Given this list of marker genes RNF4, GLYR1, SRF, GTF2A1, ARHGAP26, GAPLINC, EGLN2, TBCB, RNU2-2P, SYTL2, ELMOD3, HESX1, MRLN, CCDC136, AMD1, HS2ST1, KCNJ10, CNTD1, CAVIN2-AS1, VPS50, SNRNP40, TRIM29, UBE2F (NCBI Gene Id 23665), HNRNPH1, DAGLB, FBXO22, HSPBP1 (HSPA (Hsp70) binding protein 1), ATP5MC3 (ATP synthase membrane subunit c locus 3), B3GALT4, GATA6-AS1, MT-ND1, TCF19, LITATS1, ENSG00000235979, EXOSC9, CCNG2, PLCL2, BTNL8, LINC01393, KIAA1614, H2AC6, EDRF1, API5, IER3-AS1, SSTR5, LINC01719, LINC01833, DDX41, WDR7, TLE4, RNVU1-4, DPAGT1, CDHR3, HARBI1, INS, NOL9, LARP4B, PDHX, CNKSR3, SCRIB, C12orf76, PLK4, PRICKLE1, DHX16, RNU2-17P, LINC01767, INS-IGF2, RABGAP1L, ZBTB14, ABALON, RAB11A, BTBD3, HEXIM1, H3C1, UBB, BTBD3-AS1, ING1, GAS5, SNRPE, CNTN4, SCRT1, UTP6, GLYCTK-AS1, PRIM1, ZNF250, LDLRAP1, TMEM259, E2F5-DT, LINC01716, ZNF547, MT-RNR1, ANP32E, RNU7-1, MLXIPL, SSTR5-AS1, USP15, DCTN5 (dynactin subunit 5), HIPK1, VEPH1, SNAPC5, RMDN1, RNF139, YIF1A, GAB1, RHOA, MTCO3P12, MTHFD2L, TMCO1, LNC-LBCS, DHDDS (NCBI Gene Id 79947), KIF12, POR, PPFIA1, DDR1, SZT2-AS1, EPSTI1, DCLK1, ANKEF1, MIEF1, TCF4 (NCBI Gene Id 6925), FHAD1, CGGBP1, TARS2, LINC02417, RAB3GAP2, RNVU1-28, PPP1R37, HIPK1-AS1, ZNF181, RN7SL209P, AOAH, LPGAT1, ZBTB45, ZNF609, ZRANB3, ESCO2, UTP15, CYB5D1, ZSCAN31, JOSD2, KNL1, BRINP2, MARVELD3, RN7SL473P (RNA, 7SL, cytoplasmic 473, pseudogene), CCDC28A, C22orf46P, IGF2BP3, H4C3, PYCR3, VMP1, RNF139-DT, ARIH1, SOX6, ZNF277, NKAIN4, SNORD48, DLG2, C11orf54, MCCC1, OGT, ID4, CHGA, IER5, MAB21L4, METTL25, RAB3C, CCNH, BANCR, WEE2-AS1, FAM47E-STBD1, EIF2B5, PCYT1A, CLASP1, TLE6, RNU6-450P, UBR3, E2F5, ZFP64, ABLIM2, MUTYH, ZNRF2P3, BCKDHA, EIF3F, IREB2, GTF2H3, UPF3A, ADD1, DDX5, GPAM, DLGAP1-AS2, FOXI3, FAM76A, MTERF4, STK25P1, IDE, RNPEP, C2CD2L, IVD, FAM174C, ARID1B, CPS1, GTF2A1-AS1, MSANTD3, RRAS2, GEMIN6, PSME3IP1, ZSCAN20, ILRUN, MYLK, CLPTM1, LINC00663, KIF3B (kinesin family member 3B), LINC03002, PHB2, LINC01904, SGO1-AS1, ULK4, RPS27A, DAP-DT, TFEB, MBD1, ANXA2, RN7SKP192, ECE2, XPNPEP1, GNPDA2, SNHG11, ID1, RRP36, DHX32, GORASP2, ARID5A, IFT74, SRP68, MSI2, PKD1, EPC2, BRINP3, RMI2, TMEM177, RGS7, ENSG00000268129, GTF2H4, CTSB, TEAD1, MSI1, INO80, TM2D3, LCMT1-AS1, SLC34A1, VGF, FAM228B, PPARD, PLCE1-AS2, SEC22C, TMEM229B, H1-4, CYLD, CCDC88A, MEST, CCDC80, AATF, NBPF1, SRPRB, ENSG00000263280, GNLY, FKBP1A, LINC01320, TRAPPC12, DDX18, CAB39L, TCTA, IFT74-AS1, RMND1, CAPS2, RPL32P9, DHRS4L2, ENSG00000263080, MMP24OS, PRR5L, SNORD42B, U2SURP, HSPD1P18, ERMN, FAM47E, HOOK2, MIR3667HG, GLYCTK, FBRSL1, IZUMO4, RPL23A, VMAC, LRRC41, RNVU1-3, CCDC162P, SELENOF, FLCN (folliculin), SLC37A4, ABAT, SNHG29, KCNK16, SLC3A2, CITED2, ESYT1, ASH1L, INCENP, RAD52, RNU12, TXNDC9, MIR4259, KCNMB2, PPP2R5A, EIF2B1, LINC02351, EOLA1, TMEM41B, RAB3D, RDX, CLRN3, IDI1P1, SSBP1, EIF2A, ANKRA2, ZNF37A, STK35, APIP (APAF1 interacting protein), RPH3AL, KRT15, TMEM218, NBEA, POM121L14P, DHRS4L1 (dehydrogenase/reductase 4 like 1 (pseudogene)), KLC2-AS2, MIR367, PDZPH1P, PIGBOS1, ZNF490, TMCO1-AS1, EMC9, C4orf36, AASS, SMC4 (NCBI Gene Id 10593), C2CD3, LINC01828 (NCBI Gene Id 101927661), DKK3, TMEM205, LINC02447, EIF2AK3, RNVU1-30, LFNG, C12orf57, WDR11-DT, MED18, PABPC1L, CRIPTO, SNORA57, SDHAF3, PPME1, TMEM37, POLDIP3, SNORD68, LSM8, CPNE8, ELAPOR1, SART1, GTPBP8, VKORC1, INSM1, RRAGA, MTND5P11, TRMT10A, GALNT16, COX20, FABP1, PALB2 (NCBI Gene Id 79728), RPS21, AP4E1, SIRT4, MIR302CHG, UTP3, ALAD, OSBPL2, UPP2, RSAD1, CCNB1, RGS22, ACVR1, SYCE2, NDUFA11, SCHIP1, MT-TL1, LINC02418, PSMD1, MRPS14, NSL1, INO80B-WBP1, SF3A3, ZBTB40, RNU5D-1, GCNT2, LINC02226, ZRANB2-DT, ANK3, YTHDF2, CREB3L2-AS1, UMPS, CP, ATAD5, GMEB1, PRR3, PLA2G4E-AS1, NXN, EIF5B, WDR89, ZNF317, RND3, TMEM70, DGKE, EMG1, COPS3, ENSG00000253270, ITPR2, TTC33, WRAP53, PHLDA1-DT, FRMPD2 (FERM and PDZ domain containing 2), BRD4, GTSE1-DT, LINC01515, PDZD2, SERP1, ACOX2, REST, RGS5, ADAMTS20, R3HDML-AS1, THEM5, TADA1, DDX47, SNX16, ANKRD36, ENSG00000176984, RPL19, ALG3, TTBK2-AS1, SEMA6A-AS1, RPL7P6, ADGRA1-AS1, WDR25, RPS6KB2, TPM1, TUBB4B, GSK3B, P2RX6, ABCB1, TENM2, TADA3, ILRUN-AS1, TRIQK, CRTC2, RXRG, GIPC2, WDR27, MAP7, SNTN, MDH2, SRSF7, BDH2, FOXA2, EIPR1, RBM39, TIMP3, TRAPPC2B, PTX3, EPHA3, ODR4, FLOT1, AFP (alpha fetoprotein), MYL6B-AS1, CCHCR1, PIGB, KRBA2, MIR4487, NAGK, RPL21P42, WDR11, SLTM, S1PR5, UNC80, PCSK1 (NCBI Gene Id 5122), UQCRH, SIPA1L3, SLC35A2, GSTCD, EIF2B5-DT, H4C5, RAB1B, ENSG00000267568, RNU5F-1, MEG3, GC, RIC8B, ENSG00000199566, STC2, HMX3, RAD23A, KIF21A, OGA, TANK (TRAF family member associated NFKB activator), MAT2A, MIA3, VAMP4, SVOP, TMEM202-AS1, CDH22, EHD4, HEXIM2-AS1, LONP2, ZNF549, PHF19, WDR74, EXOSC5, ST18, HSD17B11, PHLDA1, HECTD2, CTXND1, CEP95, EIF3E, TLX2, UBE2F-SCLY, MOB3A, LINC02408, ZNF141, CNST, RNVU1-22, BSN, MIR4458HG, ARPC4, PIH1D1, ODF2L, CD164, HEY1, SAV1 (NCBI Gene Id 60485), COMT, ELF3, TMEM68, TTN-AS1, TRIM26, HDLBP, CDK12, MYL6B, RNVU1-27, STXBP1, SNHG1, SNORD26, RNVU1-21, CHGB, MYL6, TARBP2, ARPC4-TTLL3, MIDN, TMTC2, AFF1, ZNF608, EMB, RPS12, RNU6-601P, ATP5F1A, USP40, GID8, MIR302C, SNORD101, STAT1, PRKCE, CSE1L-DT, ZNF56P, SUPT5H (NCBI Gene Id 6829), FFAR1, NUSAP1, LINC01625, TP53I13, HDAC4, GLG1, STK19, HAS3, SYNGAP1, TCF12, GPC5-AS1, CCDC59, HMBOX1, CD68, RPL27A, SNORD3D, BSN-DT, TOMM40, ALKBH5, USP4, DIP2B (NCBI Gene Id 57609), ATG16L1, UBN1 (NCBI Gene Id 50641), RHOBTB3, SMG6, MIR302A, NRP1, VARS2, PRKCH, C4orf19, CSK, ALG10B, CENPU, RARB, ATP5PFP1, HGD, CCP110, KANSL3, ATP9B (ATPase phospholipid transporting 9B (putative)), CFAP276, THAP4, PTGER4, CAMK2N1, SLC46A2, AFG3L1P, SCIN, C11orf98, RGS4, MAP3K12, DDX46, DHRS4-AS1, KLF10, SNU13, TBL1X, TPR, MTFR2, TTI2, USP39, RNU4-2, FBXO46, LINC01363, ENSG00000223881, ZNF26, LRP12, CLHC1, NIN, VXN, CACUL1, ARHGEF28, UGT2B7, RNVU1-14, GRAMD2A, CNOT8, TMEM132C, FAM151B-DT, TOE1, RNU4-1, SMG7-AS1, USP54, MALAT1, TAOK1, THY1, RIF1, UBE2D1, ZNF302, EIF4E2, SMAD7, MTF2, SGK2 (NCBI Gene Id 51178), CAMSAP2, RNU5A-1, AURKA, TIMM22, KDSR, CDH8, SLC51B, OTX2, CCNO-DT, PRKRIP1, SHTN1, TAF4, SGK1, STAT3, NPL, LPCAT3, VCF1, MIR302D, UGP2, H3C10, INTS5, UAP1, DENND2A, SNAP23, ZMYND8, RPL13, TAB3, IGLVV-58, SMG7, NUMA1, CCDC159, SAC3D1, INTS6, RASGEF1B, RIOK2, KDM4A, LINC00870, CNRIP1, POLG2, PTPN1, ZNF791, FRS3, TMEM126B, MLX, LINC00970, SNHG32, SGO1, BCAR3-AS1, ARMT1, SKINT1L, DNAAF11, OSBP, CSDE1, IGLV7-46, RNVU1-2A, DOCK4, MON2, LPGAT1-AS1, TIGD1, GTSE1, CCDC28A-AS1, KMT2A, FOXA3, NRXN3, INTS9, CARS2, CLCN3, MESTIT1, GSK3B-DT, LYNX1, ZNF385B, VOPP1, MYH10, PLEKHG2, TAF5, CLU, MIR5087 (NCBI Gene Id 100847044), PDCD6P1, CSKMT, WDR5B-DT, APRT, EEF1A1, TGS1, MIR5695, NPEPL1, GBA1, LCMT1, CCNO, LINC01484, SRA1, ANAPC13, B4GALNT3, INPP4B, CBX3P9, SEC31A, COX17P1, GFOD2, DDAH2, NDUFS1, TXK, TUBB8, ZC3H12A, HSD17B6, PRDX1, ELF3-AS1, SGPL1, RABGAP1, SF3B6, CNBD2, DDIT4, MTTP, MRPS15, RNU6ATAC, TCF3, HEXIM2, HJURP, TAF1D, DYNC2I2, INTS6-AS1, RNU5B-1, ELOC, POLR1H, RGL3, MIR3183, LRRC51, MIR4673, PDZK1 (NCBI Gene Id 96133), MIR1224, POU2F1, NAA38, HNF4A, DNAH12, EPAS1, DIDO1, POLR2A, SNORD25 (small nucleolar RNA, C/D box 25), ZNHIT3, NEAT1, ENSG00000249574, WDR5B, MSH4, MEIS2, ZC3H10, ZSCAN2, ACVR1B, MAP2K6, PTPRK, ADCY9, C1orf21, RBBP5, SYMPK, VCPKMT, CCSER2, CRYZL2P-SEC16B, LINC00680, SPOCK2, NRBP1 (NCBI Gene Id 29959), PHLDB2, ASXL3, MAN1C1, LINC01972, INTS12, MOB1A, H4C2, SYBU, ENDOG, GADD45B, BUD31P1, IL34, GNL1, PDE4D, FHOD3, MPDU1-AS1, TANK-AS1, COPZ1, NALF1-IT1, SP1, DHRS4, ZNF106, ZBTB4, CAST, RETSAT, ARB2A, DXO, RNU4ATAC, ZNF329, IGSF11, PNPLA6, GATA4, HSP90AB1, FANCL, MT-TP, DNAJB4, SNORD49B, EDRF1-DT, SETDB2, COX7A2L, RHOC, STK10, EIF2AK4, NFASC, GRIK4, DPP9, SNHG5 (small nucleolar RNA host gene 5), HSD17B1, ENSG00000283078, MTCH1, TES, GREM1, CCDC150, ATG13, INO80B, POLR2M, MAP1LC3BP1, STPG1, SYT7, PRICKLE2-AS3, ANK2, EIF3A, NOL4L (NCBI Gene Id 63890), CFAP410, RHOBTB1, TATDN3, NUF2, LRIF1, BMF, TNRC6C, CRYZL2P, SNORA66, MT-TF, DDX52, MIR4512, MBD3 (NCBI Gene Id 8931), ALG14, CCDC192, ZBTB37, RAB27A (NCBI Gene Id 5873), HAUS2, CSTF1, FAM151B, FOXP4, CEBPB-AS1, POU6F2, C3orf38 (chromosome 3 open reading frame 38), GDF15, MECOM, PDE4DIPP6, JTB, CEP63, POLR1HASP (NCBI Gene Id 80869), ARL15, LENG8, BOLA1, NAV2 (neuron navigator 2), RN7SL741P, SAXO1, ZNF343, FAM13A, DRAIC, EOLA1-DT, JTB-DT, IPO4, LINC00467, SCARNA20, RPS21-DT, PDE1A, SOWAHA, USE1, IFT80, ZCCHC17, TEX55, RBM47, ENSG00000232995, ZNF804A, LINC01213, TMEM79, TUT1, HMGCR, MAP4K5, SYT17, TAFA2, SELENOW (selenoprotein W), DIO2, TTC7B-AS1, MLLT3, TNRC6B, NKTR, PARP12 (poly(ADP-ribose) polymerase family member 12), PABPN1 (poly(A) binding protein nuclear 1), CFAP45, SMG5, SS18, SART3, ZNF443, SNORD27, here is a description of the gene set: studied in species Homo sapiens Genes containing one or more binding sites for (PAX6) in their promoter regions (TSS -1000,+100 bp) as identified by GTRD version 20.06 ChIP-seq harmonization. from publication Yevshin I, Sharipov R, Kolmykov S, Kondrakhin Y, Kolpakov F (PMID 30445619) Human Gene Set: PAX6_TARGET_GENES